The following is a description of a gene set: species: Mus musculus Mouse Gene Set: GOBP_POSITIVE_REGULATION_OF_CALCIUM_ION_IMPORT_ACROSS_PLASMA_MEMBRANE Any process that activates or increases the frequency, rate or extent of calcium ion import across plasma membrane., and this is the list of marker genes: Grm6, Ppp3cb, Adrb2, Ppp3cc, Ppp3r1, Adrb1, Ppp3ca, Agtr1a (NCBI Gene Id 72294), P2rx1, Ms4a1, Ppp3r2, Akap5, P2rx5